Given this list of marker genes CTNNB1, DSPP, NFE2L1, LEF1, MSX1 (NCBI Gene Id 4487), SERPINE1, CEBPB, BMP2, RPTOR, IPO7, BMP4, here is a description of the gene set: Human Gene Set: GOBP_REGULATION_OF_ODONTOBLAST_DIFFERENTIATION studied in species Homo sapiens Any process that modulates the frequency, rate or extent of odontoblast differentiation.